The following is a description of a gene set: species: Homo sapiens Human Gene Set: GOBP_ENDOSOMAL_LUMEN_ACIDIFICATION Any process that reduces the pH of the endosomal lumen, measured by the concentration of the hydrogen ion., and this is the list of marker genes: ATP6V1F, CLCN3, ATP6V0C, ATP6AP2, ATP6V1D, ATP6AP1 (NCBI Gene Id 537), ATP6V1A, ATP6V0A1, RNASEK, AQP11, ATP6V1H, TMEM9, FASLG, ATP6V0B